Given this list of marker genes Kdm4b, Kdm2a, Kdm4c, Uty, Kdm8, Riox2, Kdm7a, Riox1, Phf8, Kdm4a, Kdm2b, here is a description of the gene set: Mouse Gene Set: GOMF_HISTONE_H3K36_DEMETHYLASE_ACTIVITY Catalysis of the removal of a methyl group from a modified lysine residue at position 36 of the histone H3 protein. This is a dioxygenase reaction that is dependent on Fe(II) and 2-oxoglutarate. studied in species Mus musculus